Given this list of marker genes NOTCH2NLB (NCBI Gene Id 100996763), ELANE, NOTCH2NLC, NOTCH2NLR, NOTCH2NLA, here is a description of the gene set: studied in species Homo sapiens part of: Pre-NOTCH Transcription and Translation <p>The <i>NOTCH2NL</i> gene family includes four genes, <i>NOTCH2NLA</i>, <i>NOTCH2NLB</i>, <i>NOTCH2NLC</i>, and <i>NOTCH2NLR</i>, which originated from the partial duplication of the first four exons and introns of the <i>NOTCH2</i> gene. Three of the duplicated genes, <i>NOTCH2NLA</i>, <i>NOTCH2NLB</i>, and <i>NOTCH2NLC</i>, reside at the chromosomal band 1q21.1, while <i>NOTCH2NLR</i> resides at 1p12, in the vicinity of <i>NOTCH2</i>. <i>NOTCH2NLA</i> was originally cloned as a gene highly expressed in white blood cells. Several studies suggest that,<i>NOTCH2NL</i> genes may have played a role in the evolutionary expansion of the human brain. <i>NOTCH2NL</i> genes are present only in the Hominidae family and, while they are functional in humans, they exist as pseudogenes in chimpanzees and gorillas. In addition, these genes are highly expressed during brain development and have the ability to delay differentiation of neuronal progenitors. The study of sequence polymorphism and copy number variation in <i>NOTCH2NL</i> genes in modern humans, and comparative analysis of <i>NOTCH2NL</i> gene sequences between modern humans, Denisovans and Neanderthals, is suggestive of an ongoing adaptive evolution of modern human <i>NOTCH2NL</i> genes trending toward lower levels of NOTCH2NL proteins. Downstream of each of the <i>NOTCH2NL</i> genes is an <i>NBPF</i> gene in the same orientation as its <i>NOTCH2NL</i> partner and co-expressed with it (<i>NBPF10</i> downstream of <i>NOTCH2NLA</i>, <i>NBPF14</i> downstream of <i>NOTCH2NLB</i>, <i>NBPF19</i> downstream of <i>NOTCH2NLC</i>, and <i>NBPF26</i> downstream of <i>NOTCH2NLR</i>), and these <i>NOTCH2NL-NBPF</i> pairs likely function in a coordinated, complementary fashion to promote neurogenesis and human brain expansion.</p><p>The neurodevelopmental disorder known as 1q21.1 distal deletion/duplication syndrome involves copy number gain or loss of the 1q21.1 chromosomal region that includes <i>NOTCH2NLA</i> and <i>NOTCH2NLB</i> genes. Copy number loss is associated with microcephaly, while copy number gain is associated with macrocephaly, and both gain and loss are accompanied with severe neurological disorders. Breakpoints within <i>NOTCH2NL</i> gene loci are also associated with neurological disorders.</p><p>Expansion of the GGC repeat in the 5’UTR of the <i>NOTCH2NLC</i> gene was identified as an important contributor to neuronal intranuclear inclusion disease (NIID) and may play a role in other neurodegenerative disorders such as Parkinson’s disease, Alzheimer’s disease, frontotemporal dementia (FTD), and amyotrophic lateral sclerosis (ALS), to name a few. The underlying pathogenic mechanism has not been elucidated. For review of <i>NOTCH2NLC</i>-related trinucleotide expansion disorders, please refer to Cao et al. 2021 and Huang et al. 2021. Reactome Pathway: Expression of NOTCH2NL genes